Given this list of marker genes DPM2, SLC35A2, COG4, GALNT2, SLC37A4, ATP6AP1, TMEM199, DPM3, here is a description of the gene set: Abnormal protein O-linked glycosylation studied in species Homo sapiens An anomaly of protein O-linked glycosylation, i.e., of the process in which a carbohydrate or carbohydrate derivative unit is added to a protein via the hydroxyl group of a serine or threonine residue. Human Gene Set: HP_ABNORMAL_PROTEIN_O_LINKED_GLYCOSYLATION